The following is a description of a gene set: Human Gene Set: chr19p13 species: Homo sapiens, and this is the list of marker genes: GPX4, ZNF414, OR1AB1P, ALKBH7, GATAD2A, OR7A18P, RPL35AP38, TLE2, TMEM259, UBXN2AP1, EPS15L1, PRR36, CYP4F11, SLC35E1, TICAM1, PGPEP1, ZNF846, ZNF440, GNG7, ICAM4-AS1, ARHGEF18, PIN1-DT, HIKESHIP2, MRPL54, TSPAN16, TBXA2R, POLR2E, KLF2, HOMER3, TUBB4A, ZNF442, ZNF57, SUGP1, FZR1, RPS15, ENSG00000267424, ZNF557, JSRP1, ADGRL1-AS1, OR7A8P, ENSG00000301105, TSSK6, TMEM167AP2, TRAPPC5, AKAP8L, GNA15, ZNF555, MAN2B1, AZU1, REXO1, RPS2P52, MIR181C, CCDC194, ILVBL-AS1, ATP5F1D, CBARP, SEPTIN14P19, MYO1F, MIR23A, JUND, RPL18A, PALM, ZNF564, CYP4F22, PBX4, RPL28P5, ZNF833P, NIBAN3, GMIP, LDLR, SLC39A3, MRPL4 (mitochondrial ribosomal protein L4), ARMC6, ASF1B (NCBI Gene Id 55723), SNORD37, ADGRE1, NANOS3, OR7A3P, ELOCP29, ZGLP1, ABHD17A, MYDGF, CC2D1A, PLPPR3, ICAM1, MRI1, BRD4, UCA1, ZNF317, STXBP2, RANBP3-DT, UNC13A, CACTIN-AS1, PRTN3, KLF16, MUC16, MPND, MBD3, CNN2, ZNF121, OR4F8P, OR4G3P, LYPLA2P2, MIR6793, ZNRF4, HAPLN4, ANO8, UBA52, LINC01842, OR7G3, PTGER1, PGLS-DT, B3GNT3, CIST1, CILP2, OR7C2, PRKCSH, TRMT1, SNAPC2, IFI30, MISP, ARHGEF18-AS1, MIR7108, NXNL1, C2CD4C, IZUMO4, PLIN3, SNORA68, FBN3, MIR3188, ENSG00000302622, ARHGAP45, OR7G1, RNA5SP468, IER2, MOB3A, RPS2P53, KISS1R, TLE6, ZNF653, COMP, GIPC3, EXOSC3P2, GNA15-DT, STK11, KXD1-AS1, MIR637, PLPP2, MIDN, MIR7-3HG, RPL17P47, CICP19, MTCO1P27, GNG14 (G protein subunit gamma 14), LSM2P1, CREB3L3, TIMM44, OR7A1P, ICAM5, PET100, PLK5, TIMM13, CDC34, MEF2B, SUGP2, SYDE1, ABCA7, OCEL1, CLEC4M, MIR1227, ZNF101, KANK3, SBNO2, MBD3L1, ZNF333, YIPF2, CYP4F23P, MED16, LSM7, HMG20B, CLEC4OP, CSNK1G2-AS1, GET3 (guided entry of tail-anchored proteins factor 3, ATPase), ENSG00000267709, CD70, HOOK2, CERS1, KLF1, GPR108 (G protein-coupled receptor 108), MIR6791, OR7A2P, RNU7-140P, YJU2, BEST2, FEM1A, OR4G1P, ACSBG2, LINC01775, LINC00663, MIR1302-11, MIR4745, FARSA-AS1, TGFBR1P1, ABHD8, ZNF700, MIR7-3, MIR638, RN7SL823P, RPL32P34, RNU6-782P, RN7SL337P, OR10H5, TRIR (NCBI Gene Id 79002), LINC01836, MIR4322, ZNF441, MIR6515, MED26 (mediator complex subunit 26), OR7D2, MARCHF2, ENSG00000291101, EIF3G, ZNF812P, RN7SL833P, TNFSF14, TMEM161A, MIR4748, CCDC124, TPGS1, MAP1S, GIPC1, P2RY11, CARM1, RN7SL231P (NCBI Gene Id 106480984), ZNF439, PKN1, LRRC25, C19orf53, POLRMT, MIR6795, PALM3, RPL7P50, KLHL26, LINC01002, SMIM44, RPL32P37, UHRF1, IL27RA, ZNF559-ZNF177, YPEL5P4, CBARP-DT, PIK3R2, RNU6-1223P, ADAMTS10, MFSD12-AS1, TMEM221, MAST1, RNU6-1076P, TMEM59L, CDKN2D, ZNF763, FDX2, NFILZ, ARID3A, XAB2, RAB3D, KRI1, OR7D4, OR7H1P, IQCN, RETN, SEMA6B, INSR, DPP9-AS1, RPS15P9, KXD1, HDGFL2, CRLF1, FSTL3, CASP14, ELAVL1, CFD, SGTA, USE1, RFX1, ZNF699, SNRPGP15, APC2, PRAM1, OR7A10, DUS3L, INSL3, OR1M4P, UQCR11, ZNF560, RPL21P129, ICAM3 (NCBI Gene Id 3385), ADGRE4P, CDC37, NMRK2, CYP4F3, ZNF358, CYP4F12, FBXL12, TGFBR3L, ELL, ZNF823, ZNF563, SIRT6, USHBP1, SYCE2, ZNF799, UBL5, ACTL9, MVB12A, BNIP3P9, REEP6, SPC24, MIR1909, FGF22, PODNL1, C19orf25, NFIC, CYP4F24P, ENSG00000287960, COL5A3, BORCS8-MEF2B, RFX2, ZNF844, ZNF491, SAFB, GDF15, WDR83OS, PRSS57 (NCBI Gene Id 400668), NDUFA7, WDR18, KDM4B, PDE4C, NWD1, BISPR, NDUFA11, OR1M1, TINCR, ACP5, ATP8B3, RPL36, OR7A17, ENSG00000295083, FCHO1, TEKTIP1, AKAP8, OAZ1, RPL18AP13, MIR1238, SSBP4, PIP5K1C, RN7SL202P, OR10H4, S1PR5, LINGO3, NR2F6, ZBTB7A, TIMM29, ZNF20, NDUFA13, WASH5P, SNORD105B, C19orf38, CLEC17A, LSM4, PLIN4, DNASE2, ATCAY, ECSIT (ECSIT signaling integrator), ADGRE2, HSD11B1L, MPV17L2, RN7SL835P, HMGB2P1, CD209, TPM4 (NCBI Gene Id 7171), KANK2, DNAJB1, ELOCP28, RANBP3, RN7SL146P, MYO9B, HOMER3-AS1, ZNF253, MFSD12, DNMT1, R3HDM4, MIR6885, OR4F17, SNX33P1, PTPRS-AS1, TMED1, MIR1470, OR7E16P, MARK2P21, ODAD3, MAP2K7, DDX49, RN7SL842P, MAST3-AS1, ONECUT3, REX1BD, RNA5SP467, ZNF56P, C19orf67, TM6SF2, TRIP10, MIR6886, OR7G2, CTXN1, RN7SL192P, ZNF709, STAP2, MBD3L2, SLC25A41, EBI3, ZNF14, TCF3, SF3A2, DDX39A, OR7C1, TNPO2, RPS6P25, CAMSAP3, PHF5AP1, HNRNPM, RASAL3, GAPDHP76, ARRDC5, SHFL, QTRT1, TEKTL1, MIR3189, BRME1, RAB11B-AS1, CELF5 (CUGBP Elav-like family member 5), PNPLA6, FKBP8, KHSRP, LINC00905, MEX3D, FSD1, GAMT, ITGB1P1, NFIX, FARSA, ZSWIM4, SPPL2B, SH3GL1 (SH3 domain containing GRB2 like 1, endophilin A2), EFNA2, ILF3, FAM32A, MIR27A, C3P1 (NCBI Gene Id 388503), LPAR2, MIR24-2, PRKACA (protein kinase cAMP-activated catalytic subunit alpha), UBXN6, PCSK4, RN7SL619P, SHD, MAST3, MKNK2, SIN3B, RNA5SP466, ENSG00000274447, TNFAIP8L1, WIZ, SMARCA4, RPL23AP78, MBD3L4, LMNB2, OR7A15P, KCNN1, RTBDN, BNIP3P10, JUNB, DENND1C, RGL3, GADD45B, HCN2, DHPS, CRB3, ZNF562, RNU6-2, PDE4A, CLIC4P2, UPF1, THOP1, TMEM205, LIMASI, TMPRSS9, ICAM4, GCDH, ZNF887P, F2RL3, MICOS13, NRTN, ZNF625-ZNF20, MCOLN1, MIR5695, DPP9, MIR4999, CHERP, ARRDC2, AP1M2, CYP4F36P, RNU6-1028P, MAP2K2, MBD3L5, TYK2, PCP2, RNA5SP464, ZNF426-DT, TMIGD2, COLGALT1, PIAS4, FUT5, ZNF433-AS1, TNFSF9, MIER2, SNRPEP4, NDUFB7, ANGPTL4 (angiopoietin like 4), CYP4F9P, CACTIN, PLIN5, SCAMP4, PGK1P2, ENSG00000290008, ELAVL3, ATG4D, MIR5684, ZNF554, PGLS (NCBI Gene Id 25796), MIR5589 (NCBI Gene Id 100847093), CLEC4GP1, EEF1DP1 (NCBI Gene Id 126037), NOTCH3, SWSAP1, NCAN, MIR1199, ZNF44, RPL21P130, MISP3, RLN3, IL12RB1, OR10B1P, RNA5SP462, ZNF506, DAPK3, PEX11G, OR10H2, FCER2, ZNF177, RPL10P15, OR7E18P, RPS12P32, ANKLE1, ATP13A1, ANGPTL6, JAK3, ISYNA1, DOCK6-AS1, RPS4XP22, CRTC1, RFXANK, MTATP6P27, MATK, DAZAP1, AP3D1, LRRC8E, SLC27A1, CALR3, CCDC159, MADCAM1, ADAT3, RNF126, MIR640, BOLA3P2 (bolA family member 3 pseudogene 2), MBD3L2B, RNA5SP465 (NCBI Gene Id 100873709), NACC1, ZNF878, MBD3L3, NR2C2AP (NCBI Gene Id 126382), PLPPR2 (NCBI Gene Id 64748), RDH8, ELANE, MCEMP1, RN7SL70P, ADGRE5, GNA11, OR7G15P, WBP1LP11, MIR6790, GDF1, HNRNPA1P10, DOT1L, FBXW9, SLC1A6, RN7SL155P, OR2Z1, OR1I1, ZNF558, ZNF556, ZNF136, CERS4, EEF2, DOHH, ZNF625, SNORA70, BABAM1, ILF3-DT, ZNF433, NCLN, SAMD1 (sterile alpha motif domain containing 1), ZNF559, SMIM7, RPL35P10, PRDX2, PRR22, EPOR, RPL12P42, PLEKHJ1, VAV1, ADGRL1, ZNF426, SMIM46, MIR4321, NDUFS7, THSD8, SLC25A42, HSH2D, COPE, UCA1-AS1, RPS27AP19, RPS18P13, RPL39P38, UBE2L4, EPHX3, CACNA1A, SNORD41, PLVAP, VMAC, LINC02926, RN7SL121P, ADGRE3, LINC01841, LRG1, RSL24D1P8, MIR6792, ZNF69, HAUS8, AP1M1, SLC5A5, GTF2F1, FUT6, MIR199A1 (NCBI Gene Id 406976), CIRBP, C19orf44, ENSG00000267174, ZNF266, APBA3 (amyloid beta precursor protein binding family A member 3), TMEM38A, OR7E25P, RNU6-9, ZNF861P, CAPS, PPAN-P2RY11, FUT3, ZNF443, SNORD105, RNASEH2A, MLLT1, OR7A11P, MIR7974, ZNF788P, ENSG00000267122, ZNF791, ACER1, PEAK3, KEAP1, OR10H3, CLPP, MRPL34, C3, RN7SL477P, CSNK1G2, RAB8A, CHAF1A, TECR, S1PR2, OR7E19P, MAU2, DAND5, ZNF561-AS1 (NCBI Gene Id 284385), ELOF1, FAM138F, YJU2B, SH2D3A, PIN1, CD320, MIR7850, SAFB2, MIR23AHG, MIR3940, RAX2, LYL1, BSG-AS1, RPL10P16, MIR6789, MIR6794, GZMM, MIR1181, PSPN, CPAMD8, PPIAP20, ZNF490, FTLP5 (NCBI Gene Id 100131661), RAVER1, SAXO5, ILVBL, CATSPERD, CCL25, SLC25A23, RAB3A, DDA1, KLF2-DT, GRIN3B, DCAF15, WDR83, OR10H1, PGLYRP2, DNM2, ANGPTL8, DOCK6, ZNF77, MIR181D, ZFR2, SHC2, RPS29P23, CLEC4G, FAM174C, DIRAS1, PTPRS, RNU6-993P, RAB11B, CALR, RAD23A, GTPBP3, BORCS8, OR7D1P (NCBI Gene Id 26656), PPAN, CIRBP-AS1, ENSG00000272473, MIR3187, BST2, MIR4747, EVI5L, PWWP3A, CYP4F2, S1PR4, ZNF561, CYP4F8, STX10, OLFM2 (NCBI Gene Id 93145), LINC00661, RPS28, SMIM24, TLE5, RN7SL513P, YJEFN3, CYP4F10P, MIR639, MTCO2P27, LONP1, ENSG00000267448, OR7A5, RPL23AP2, ANKRD24, OR7E24, MTND2P40, CIB3, ADAMTSL5, MIR4746, BTBD2 (NCBI Gene Id 55643), PTBP1, AMH, GADD45GIP1, BSG, SPMAP2, EIF1P6, MADCAM1-AS1, CNN1, ZNF627, TJP3, CIMAP1D, SLC44A2